Given this list of marker genes Hsd11b1, Mlst8, Aldob, Mtor, Rptor, Tigar, Hnf1a, Me2, Me1, Trp53, here is a description of the gene set: Any process that modulates the frequency, rate or extent of NADP metabolic process. studied in species Mus musculus Mouse Gene Set: GOBP_REGULATION_OF_NADP_METABOLIC_PROCESS